Given this list of marker genes NFKB1, PPP3R1, MIR1-2, TGFB1, MIR1-1, MIR21, STAT3, MIR29A, RASGRF1, MIR133B, AKT1, AKT2, MIR125B1, MYEF2, MIR125B2, here is a description of the gene set: species: Homo sapiens Transcription factors regulate miRNAs related to cardiac hypertrophy Human Gene Set: WP_TRANSCRIPTION_FACTORS_REGULATE_MIRNAS_RELATED_TO_CARDIAC_HYPERTROPHY